The following is a description of a gene set: Childhood acute lymphoblastic leukemia (ALL) is curable with chemotherapy in approximately 80 percent of patients. However, the cause of treatment failure in the remaining 20 percent of patients is largely unknown. Human Gene Set: HOLLEMAN_DAUNORUBICIN_B_ALL_DN Genes distinguishing daunorubicin resistant and sensitive B-lineage ALL; here - genes down-regulated in the drug resistant samples. from publication Holleman A, Cheok MH, den Boer ML, Yang W, Veerman AJ, Kazemier KM, Pei D, Cheng C, Pui CH, Relling MV, Janka-Schaub GE, Pieters R, Evans WE (PMID 15295046) species: Homo sapiens, and this is the list of marker genes: RHOA, GMEB2, MED28, NTAN1, ARID4A, PCBP2, PPDPF, ING3, SHOC2, CTDSP2, LSM8, CTCF